The following is a description of a gene set: Genes predicted to be targets of miRBase v22 microRNA mmu_miR_103_1_5p in miRDB v6.0 with MirTarget v4 prediction scores > 80 (high confidence targets). species: Mus musculus Mouse Gene Set: MIR_103_1_5P from publication Chen Y, Wang X (PMID 31504780), and this is the list of marker genes: Akap10, Plcxd2, Ammecr1, Dolk, Rgl1, Pdgfd, Stx17, Scd3, Samd3, Cyld (CYLD lysine 63 deubiquitinase, NCBI Gene Id 74256), Rnf152, Itm2b, Galnt13, Robo2, Mkrn1, Alkal1, Gab2, Cbx6 (NCBI Gene Id 494448), Ica1l, Ndst3, Slc17a8, Bbs10, Nhsl2, Cab39l, Bbx, Cdh12, Gclm, Mbnl2, Slc6a15, Dach1, Ash1l, Fam174a, Slc8a1, Pdzd2, Rnpc3, St8sia3, Dyrk1a, Zbtb5, Tor1a, Mtch2, Mab21l2, Cyct (cytochrome c, testis), Susd6, Rala, U2surp, Man2a1, Trak1, Hnrnpa2b1, Pwwp2a, Son, Nav1, Cdnf, Ptprr, Atrn, Tmx2 (NCBI Gene Id 66958), Cux1, Dnm3, Rps15a, Mtmr1, Micu3, Tbx2, Ing5, Nedd4l, Zbtb24, Lpcat2b, Dipk2b, Pitpnm2, Il17rd, Mtr, Vps29, Fxr1, Ankrd13b, Slc38a2, Tnpo1, Rbm27, Rgs1, Bmi1, Nedd9, Taf12, Prkaa2, Tardbp, Arsa, Grk3, Rcn1, Phaf1, Nr3c1, Hyal6, Tada2b (NCBI Gene Id 277862), Rspo3, Grm7, Lurap1l, Tacr2, Dlc1, Fat3, Ginm1, Zfp827, Gria4, Tsc22d2, Ngef, Lipa, B230219D22Rik, Hccs, Naa30, Wsb1, Ipcef1, Sec23ip, Adar, Pnma8b, Fam120b, Gpr82, Cxcr2, Dusp3, Tnrc6b, Slc15a2, 1700066M21Rik, Cdh11, Mysm1, Mctp2 (NCBI Gene Id 244049), Stra6l, Usp31 (ubiquitin specific peptidase 31), Smarca4